Given this list of marker genes Pcdha4, Gap43, Nfib, Snx19, Zfp429, Pafah1b1, Klhl24, Magea1, Map7d3, Etv1, Pcdha1, Rpgrip1l (NCBI Gene Id 73313), Pigg, Zfp704, Atp6v0e, Spin1, Sgip1, Ccng1, Pcdhac2, Pcdha11, Notch3, Fgr, Pcdha7, Brwd1, Pcyt1a, Igdcc4, Magea8 (MAGE family member A8), Slc22a23 (NCBI Gene Id 73102), Nhsl2, Scfd2, Hus1 (NCBI Gene Id 15574), Gramd2b, F5, Prkd3 (protein kinase D3), Mcu, Unc80, Lox, Adamts10 (NCBI Gene Id 224698), Tcf4, Trak1, Camsap1, Elp4, Sigmar1, Rab11fip2, Pcdha5, Pi15, Pcdhac1, Csmd3, Hibadh, Pcdha2, Chka, Chd7, Pcdha3, Fam131b, N4bp1, Pcdha9, Csrnp1, Traf3, Akr1c21, Pcdha12, Dpf2, Adgrb2, Pcdha6, Map3k20, Magea2, Mapk10, Skap2, Mea1, Pbx1, Card19, Tm9sf2, Nkx3-1, Gtf2e1, Pcdha10, Cltc, Dock1, here is a description of the gene set: studied in species Mus musculus Genes predicted to be targets of miRBase v22 microRNA mmu_miR_759 in miRDB v6.0 with MirTarget v4 prediction scores > 80 (high confidence targets). from publication Chen Y, Wang X (PMID 31504780) Mouse Gene Set: MIR_759